The following is a description of a gene set: Mouse Gene Set: GOMF_PROTEOGLYCAN_SULFOTRANSFERASE_ACTIVITY studied in species Mus musculus Catalysis of the reaction: 3'-phosphoadenosine 5'-phosphosulfate + proteoglycan = adenosine 3',5'-bisphosphate + proteoglycan sulfate. A proteoglycan is a glycoprotein whose carbohydrate units are glycosaminoglycans., and this is the list of marker genes: Chst9, Chst12, Hs3st5, Ndst3, Ust, Hs3st3a1, Hs3st3b1, Chst14, Hs3st2, Ndst1, Hs6st1, Ndst2, Chst11, Hs6st3, Chst13, Chst8, Chst7, Chst1, Hs2st1, Hs3st6, Ndst4, Hs6st2, Hs3st4, Chst3, Chst5, Hs3st1